The following is a description of a gene set: species: Mus musculus The developmental process pertaining to the initial formation of a camera-type eye from unspecified neurectoderm. This process begins with the differentiation of cells that form the optic field and ends when the optic cup has attained its shape. Mouse Gene Set: GOBP_EMBRYONIC_CAMERA_TYPE_EYE_FORMATION, and this is the list of marker genes: Pax2, Twist1, Sox11, Phactr4, Arid1a, Aldh1a1, Prox1, Aldh1a3, Frs2, Stra6, Tfap2a